The following is a description of a gene set: Genes down-regulated in comparison of CD25+ T effector cells treated with IL4 at day 3 versus untreated CD25- T cells at day 3. from publication Prots I, Skapenko A, Lipsky PE, Schulze-Koops H (PMID 21347372) Human Gene Set: GSE24634_TEFF_VS_TCONV_DAY3_IN_CULTURE_DN species: Homo sapiens CD25+ regulatory T cells develop in the thymus (nTregs), but may also be generated in the periphery upon stimulation of naive CD4 T cells under appropriate conditions (iTregs). The mechanisms that regulate the generation of peripheral iTregs are largely unknown. We used microarrays to gain insights into the molecular program of extrathymic Treg development., and this is the list of marker genes: CCRL2, IMPA2, FCGRT (Fc gamma receptor and transporter), CTSA, CCL4, ECM1, OSBPL1A, IDH1, GNS, TKTL1, PPFIBP2, IFI30 (NCBI Gene Id 126359), MCF2L-AS1, NAGLU, TLR1, HNMT, SLC38A6, SLC22A18 (solute carrier family 22 member 18), FIG4, CHMP7, FGR, ZNF652, EVI2B, DRAM1, CRYL1, C2, UGGT2, BTN3A3, SQOR, KANK1, ACP2, P2RY13, HMOX1, ADAP2, H2BC21, SELL, MCOLN1, ERP44, CLEC4E, MANBA, HEXA, RIN2, CD163, CLEC4A, LILRB2, CASP8, CITED2, CYP27A1, ZSCAN32, VSIG4, TM9SF1, EPPK1, SLAMF8, EVL, SAMHD1, PARP6, THEMIS2, MAN1C1, MNDA, SNCA, SPINT2, LAIR1, ZNF32, MARCO, MCUB, RNASE6, ATP6AP1, PLAAT4 (phospholipase A and acyltransferase 4), LIPA (NCBI Gene Id 3988), SPRY2, SERPINA1, PSTPIP2, BCAP31 (B cell receptor associated protein 31), MPP1, SYK, OPN3, NTAN1, GIMAP5, CD68, TCF7, SLC11A1, NRP1, THBS1, ST3GAL1, SLC12A7, KLF6, SORT1, ABCG1, GPR35, NPL, SLC31A2, AOAH (NCBI Gene Id 313), PYGL, CTSL, GLB1, FOS, GUSBP14, MAGED2, KCTD12, CCL2, KYNU, KBTBD11, GSAP, SDR39U1, DIAPH2, COL19A1, ZNF185, ADA2, CD84, FCGR2A, CALCR, SLC2A9, TLR8, CCR1, RUNX1T1, GSTA1, NPC1 (NPC intracellular cholesterol transporter 1), H1-2, GLB1L, FHIT, FGL2, HSD3B1, CREBL2, CD1D, LHPP, DAB2, TNFRSF14, FCER1G, ITGB5, STOM, GPA33, SERPING1, FCN1, FBXW4P1, CPVL, HLA-DMA, MYOF, MX2, FBXW4, VAMP3, MERTK (NCBI Gene Id 10461), MFSD1, HLA-DRB6, RNH1, CCPG1, MS4A4A, HCK, ADM, LGALS3BP, ADAM9 (ADAM metallopeptidase domain 9), APBA2, TMEM50A, IKZF3, PILRA, C1QA, SEPTIN10, AKR1A1, CYBB, SMCO4, LY96, PDGFC, YIPF1, TCEAL1, LTBP2, ABLIM1, APLP2, HLA-J, NAGK, CAT, CD14, NCF1C, DYSF, TP53I3, SMIM27, PGD, CLEC2B, TLR2, TYMP, CHST15, ITGAX, NCF2, PDCD4-AS1, CD302, MAN2B1, RXRA, RGL1, NUCB2, CDKN1A, EPB41L3, RB1, RETREG2, S100A8, CCR5, LILRB4 (NCBI Gene Id 11006), LPAR6, CEBPB, FKBP15, SLC7A7, CTSO, MAFB